Given this list of marker genes ALOXE3, ALOX12, CYP2C9, PLA2G4C, CYP2B6, FAAH2, MGLL, CYP4F11, CYP4F12, CYP2D6, ALOX15B, CYP2F1, CYP4F8, CYP4A11, CYP4F3, GPX4, FAAH, PLA2G2F, AWAT1 (acyl-CoA wax alcohol acyltransferase 1), CYP2C8, CTHRC1, CYP2C19, CYP4Z1, CYP2S1, PNPLA8, CYP2A6, CYP4A22, PLA2G4B, PLA2G4A, MGST3, ALOX12B, CYP4F2, PTGS2, ABHD12, CYP2U1, CYP1A1, GPX1, DAGLA, PTGS1, CYP2E1, ALOX5, CYP1A2, CYP2A7, ABHD6, EPHX1 (epoxide hydrolase 1), ALOX15, PLA2G10, CYP2C18, CYP2A13, DAGLB, CYP2J2, CYP1B1, here is a description of the gene set: The chemical reactions and pathways involving arachidonic acid, a straight chain fatty acid with 20 carbon atoms and four double bonds per molecule. Arachidonic acid is the all-Z-(5,8,11,14)-isomer. Human Gene Set: GOBP_ARACHIDONATE_METABOLIC_PROCESS species: Homo sapiens